The following is a description of a gene set: Human Gene Set: HP_ERYTHEMA_NODOSUM Erythema nodosum An erythematous eruption commonly associated with drug reactions or infection and characterized by inflammatory nodules that are usually tender, multiple, and bilateral. species: Homo sapiens, and this is the list of marker genes: ERAP1, IL23R, STAT4, LRBA, HLA-B, UBAC2, FAS, CCR1, NOD2, XIAP, KLRC4, PIK3R1, NLRP12, ADA2, IL12A, LBR, MEFV, IL10, HLA-DRB1, IL12B, IL12A-AS1, C4A, MLX, BTNL2, TLR4, PSMB8, IFNGR1